The following is a description of a gene set: Human Gene Set: GOBP_POSITIVE_REGULATION_OF_CELL_PROLIFERATION_INVOLVED_IN_KIDNEY_DEVELOPMENT Any process that activates or increases the frequency, rate or extent of cell proliferation involved in kidney development. studied in species Homo sapiens, and this is the list of marker genes: MYC, LIN28A, IL6R, SERPINB7, CFLAR, ITGB3, EGR1, PDGFD, PDGFB